The following is a description of a gene set: Any process that modulates the rate, frequency, or extent of inclusion body assembly. Inclusion body assembly is the aggregation, arrangement and bonding together of a set of components to form an inclusion body. Human Gene Set: GOBP_REGULATION_OF_INCLUSION_BODY_ASSEMBLY studied in species Homo sapiens, and this is the list of marker genes: HSPA1B, DNAJB2, APOE, DYRK1A, MIR219A1, PSMC5, DNAJB8, HSPA2, DNAJB6, SNCAIP, DNAJB1, PPP2CB, SORL1, HSPA1A, IFNB1, CLU, SACS, PSMC6, DNAJA4, MARK2, BAG5, HSF1